The following is a description of a gene set: Calcium signaling is a central regulator of cardiomyocyte growth and function. Calmodulin is a critical mediator of calcium signals. Because the amount of calmodulin within cardiomyocytes is limiting, the precise control of calmodulin expression is important for the regulation of calcium signaling. In this study, we show for the first time that calmodulin levels are regulated posttranscriptionally in heart failure. The cardiomyocyte-restricted microRNA miR-1 inhibited the translation of calmodulin-encoding mRNAs via highly conserved target sites within their 3' untranslated regions. In keeping with its effect on calmodulin expression, miR-1 downregulated calcium-calmodulin signaling through calcineurin to NFAT. miR-1 also negatively regulated the expression of Mef2a and Gata4, key transcription factors that mediate calcium-dependent changes in gene expression. Consistent with the downregulation of these hypertrophy-associated genes, miR-1 attenuated cardiomyocyte hypertrophy in cultured neonatal rat cardiomyocytes and in the intact adult heart. Our data indicate that miR-1 regulates cardiomyocyte growth responses by negatively regulating the calcium signaling components calmodulin, Mef2a, and Gata4. Human Gene Set: IKEDA_MIR133_TARGETS_DN species: Mus musculus from publication Ikeda S, He A, Kong SW, Lu J, Bejar R, Bodyak N, Lee KH, Ma Q, Kang PM, Golub TR, Pu WT (PMID 19188439) Genes down-regulated in hypertrophic hearts (due to expression of constitutively active form of PPP3CA) and predicted to be targets of miR-133 microRNA., and this is the list of marker genes: BTBD3, MEF2C, ASPH, RB1CC1, PPP1R3A, PRRX1